Given this list of marker genes ENSG00000223881, ENSG00000285280, PRG4, SLC4A1APP2, LINC01036, PDC-AS1, RNA5SP73, ODR4, NEK7, RPS3AP9, LINC02770, CLPTM1LP1, LINC01701, KCNT2, RGS18, LINC01680, PEBP1P3, RPL23AP22 (NCBI Gene Id 100271291), CFHR3, CFHR1, FDPSP1, LINC01720, FAM204BP, ZNF101P2, CDC73, RN7SKP156, RGS1, PTPRC, RPS27AP5, C1orf53, RGS2, HNRNPA1P46, GLRX2, LINC03121, ATP6V1G3, GAPDHP75, UCHL5, CFHR4, BRINP3-DT, PRR13P1, BRINP3, SCARNA18B, F13B, LINC01724, B3GALT2, CFHR5, ASPM, RGS13, LINC01035, PTGS2, MIR4735, PACERR, DENND1B (DENN domain containing 1B), CFHR2, MRPS21P3 (NCBI Gene Id 359767), EEF1A1P32, LINC01031, MIR4426, RN7SKP126, RNU6-1240P, PDC, MIR1278, SEPTIN14P12, EEF1A1P14, CRB1, RO60, ENSG00000289995, ENSG00000288078, LHX9, ENSG00000287364, RNU6-983P, PLA2G4A, RGS21, CFH, TPR, ZBTB41, here is a description of the gene set: Human Gene Set: chr1q31 species: Homo sapiens